The following is a description of a gene set: Genes up-regulated in comparison of unstimulated dendritic cells (DC) versus 1 day DC stimulated with LPS (TLR4 agonist). Immune cell-specific expression is one indication of the importance of a gene's role in the immune response. In order to identify such patterns, we set out to broadly profile gene expression in a variety of immune cells. from publication Abbas AR, Baldwin D, Ma Y, Ouyang W, Gurney A, Martin F, Fong S, van Lookeren Campagne M, Godowski P, Williams PM, Chan AC, Clark HF (PMID 15789058) Human Gene Set: GSE22886_CTRL_VS_LPS_24H_DC_UP studied in species Homo sapiens, and this is the list of marker genes: SDHAF3, GPHN, RPL27, PDIA4, RPS14, RPS18, ATP5PD, CLEC10A, NDUFB1, GLRX5, MARCHF1, CDIPT, CAMK1, MLEC, EIF3L, ARMCX5, CD209, TACC1, CDK19, TMEM243, TMEM9B, ESYT1, WASHC5, DEF6, PON2, TRAM2, EIF3K, ACO2, LAPTM4B (NCBI Gene Id 55353), GTF2A2, PCYOX1L, GNAS, ISYNA1, IFNGR1, ARHGEF6, MAF, NDUFB5, GPX1, GEMIN6, FLI1, CERK, IMPA2, BRPF1, PABPC4, ACTR2, PPIH, ADCY7, PNPO, RTN3, MAPK14, MRPL3, CHEK2, HSD17B10, LMO2, CD36, TMT1A, ZMYM3, WDR37, RPLP2, ATP5MC1, TRAPPC6A, CHPT1, POLD2, COPS4, ANAPC13, MAP1S, PABPC1, RAB7A, SLC16A1, NACA, GLIPR1, CYREN, EBNA1BP2, MGAT4A, S100B, TXNRD3, FIS1, ORAI3, COTL1, TBXAS1, GDE1 (NCBI Gene Id 53591), BAG5, RPL30, NDUFA4, SLC12A9, HLA-DMA, APEX1, CALM2, EGLN1, DOCK2, DOK2, EIF2B1, MGST2, DNMT1, F13A1, P4HTM, HAT1, NDUFC2, TM6SF1, SLAMF8, CDC40, SNX5, MS4A6A, DIAPH1, RPL39, NRP1, ARHGAP4, RRP1B, TRIM32, PDLIM2, PPP1R7, LSM7, RCOR1 (REST corepressor 1), APBB1IP, FBXW2, HGSNAT, POGK, GRAMD4, TMEM147, VASH1, PSTPIP1, ZBTB11, RNMT, TCEAL1, ROGDI, GOT2, PLCB2, EIF2D, SLC48A1, CETN2, ARFIP1, FOCAD, COPZ1, STX10 (syntaxin 10), FAM168B, EIF4B, AP1B1, EEF1B2, ALDH3A2, PEMT, CYFIP1, RPS3A, ADORA3, SYK, AP1S2, TOP2B, EXOSC5, PTDSS1, POP5, HHEX, COMMD10, VAMP8, GMPR2, CTDSP1, FES, ATP5PB, SEC24D, UQCR10, MYG1, UBE2E3, PTGS1, CXCR2, COX7C, CBFB, NT5DC2, EIF3B, ABCE1, SKIC8, RNF113A, GPD1L, ADCK2, S100A4, BICD2, BDH1, SH3BGRL, FRAT2 (FRAT regulator of WNT signaling pathway 2), IL16, CAPZA2, RAP1A, UFSP2, SLCO2B1, COX8A, MAST3, ECSIT, MRM2, LAT2, CHCHD7, FCGR2B, TBL1XR1, UQCRH, HS2ST1, SUCLG2, MSRA, GCA (grancalcin), RPS8, ZCCHC24, NRGN, NDUFV1, CDK5, RPS13